Given this list of marker genes CDKN1C, POMGNT1, FOXE1, ARID1A, GTF2IRD1, KCNMA1, FBN2, NEK9, HESX1, SGCA (sarcoglycan alpha), EHMT1, TPO, FKBP6, POMGNT2, TBX3, MTMR14, MAP3K7, JAG2, SGCB, MYMK, DHX16 (NCBI Gene Id 8449), KCNQ1, FUCA1, ACTA1, ATP6V1B2, AFF4, DNM2, LIMS2, PMP22, IL6ST, EIF4H, KCNA1, INSR, POGZ, FDX2, ALG3 (ALG3 alpha-1,3- mannosyltransferase), CNBP, CHCHD10, MYH7 (myosin heavy chain 7), RNF125, USF3, ELN, MEG3, ATRX, KLLN, VAPB, PRKAG2, LMX1B, HBB (NCBI Gene Id 3043), LHX3, SDHD, SGCG, CUL4B, TRAF3IP2, HNRNPK, SGCD, B4GAT1, TGFBR1, SHOX, TTN, GNE, PLIN1, FLNA (filamin A), IGF2, SELENON, VPS33A, SAA1, DAG1 (NCBI Gene Id 1605), DVL1, IFT140, PLXND1, PPARG, PLAAT3, PAX8, MAN2B1, PIEZO2, RYR1, METTL27 (methyltransferase like 27), LTBP4, DMD, RASA1, SMAD4, HSPG2, SMN1, GMPPB, LIMK1, FRG1, CRPPA, POLR3A, AGA, FLVCR2, SDHC, GTF2IRD2, FKTN, BUD23, GPR101, MYF6, BAZ1B, FKRP, PIK3C2A, FIBP, GAA, ALG8, DLK1, IYD, DNAJC30, ZFX, TRPV4, CAV3, HACD1, TBCK, PQBP1, BIN1, GUSB, IDS, GRIA3 (NCBI Gene Id 2892), CLIP2, POU1F1, GLE1, PTEN, PIGW, CCDC47, POPDC3, CAV1, UNC45B, SLC26A4, TPM2, AIP, GPC3, STX1A, CPSF3, TSHB, HRAS, ALG6, TCAP, ARCN1, SPG11, SIL1, PSMB8, TBL2, CLCN1, ITGA7, POMT2, STT3A, AKT1, LIPE, FHL1, ITPR1, HEXB, DUOX2, SMARCB1, SNRPN, AR, ZBTB24, KCNN3, GNS, LHX4, ATP2A1, RFC2, GNPTAB, CHRND, MFN2, DUOXA2, TPM3, ROR2, ZFP57 (ZFP57 zinc finger protein), TG, PRPS1, GLB1, TBX5, ERLIN2 (NCBI Gene Id 140906), MSTN, SETBP1, CAPN3, WNT5A, PIK3CA, BSCL2, ZEB2, CHRNA1, LARGE1, IPO8, AMPD2, KCNH5, ARSB, POMT1, GPC4, BMP4, MBD5, HELLS, INPP5E, COLEC11, SEC23B, CDCA7, CHRNG, SNIP1, HYMAI, ALG9, CIZ1, KCNH1, SCN4A, PIGS, KCNJ11, MYMX, LAMA2, CAVIN1, SNX14, UBE3A, TMEM270, MPZ, GTF2I, MYL2 (myosin light chain 2), VPS37D, RTL1, MAP3K20, NKX2-1 (NK2 homeobox 1), THRA, NCF1, SLC25A1, HMGCR, SRY, DPM3 (NCBI Gene Id 54344), COL4A1 (NCBI Gene Id 1282), SDHB, MT-TE, REV3L, ABCC8, MAN2C1, SMARCA4 (NCBI Gene Id 6597), DNMT3B, ANO5, RMRP, MED13L, SALL4, HS2ST1, FOS, NKX2-5, TRMU, KCNQ1OT1, PLEC, UHRF1, DYSF, AGPAT2, TSHR, ACTB, CIDEC, POMK (NCBI Gene Id 84197), RBM8A, IDUA, PROP1, SLC5A5, B3GALNT2, RNU4-2, ATP6V0A2, PEX1, LMNA, POP1, PLAGL1, MICU1, FOXG1 (forkhead box G1), RXYLT1, here is a description of the gene set: Human Gene Set: HP_ABNORMALITY_OF_MUSCLE_SIZE Abnormality of muscle size species: Homo sapiens Abnormalities of the overall muscle bulk based on clinical observation.